Given this list of marker genes SLC27A3, SLC27A2, SLC27A5, ACSL4, ACSBG1, SLC27A6, SLC27A1, ACSBG2, ACSF3, SLC27A4, here is a description of the gene set: Catalysis of the reaction: a very long-chain fatty acid + ATP + CoA = a very long-chain fatty acyl-CoA + AMP + diphosphate. A very long-chain fatty acid has an aliphatic tail containing more than 22 carbons. species: Homo sapiens Human Gene Set: GOMF_VERY_LONG_CHAIN_FATTY_ACID_COA_LIGASE_ACTIVITY